Given this list of marker genes TYRO3, LDLRAP1, FAM20B, VSTM4, TENM4, PSEN2 (NCBI Gene Id 5664), RAB11FIP3, SETD4, ABCD2, LSM4, GAB1, DNAH2, CREG1, NOTCH1 (notch receptor 1), IGFBP4, PILRA, TMC7, PALD1, C2CD2, KRT1, UBTD1, CTTN, BAG3, MAPKBP1, RASSF3, SEZ6L2, UNC13B, DOT1L, TTF1, ALDH1L1 (NCBI Gene Id 10840), ST6GALNAC2, GLI2, SSUH2 (ssu-2 homolog), ALDOAP2, TPP1, ANGPTL3, GPD1, AATK, MYO7A, DOK3, FABP4, NUAK1, BBOF1, PELP1, HACD4, MAGED1, SYNPO, AQP1, MUC15, GBP6, OPTN (NCBI Gene Id 337928), ADAMTSL2, SNX8, ARL4A (ADP ribosylation factor like GTPase 4A), ACTL6B, IL18, IGSF8, CCL22, LRP1, SLC12A7, MRAS, ARAP1, SCAMP5, TMEM117, ARHGAP23, GTF2IRD1, PPARGC1B, C4orf54, NCEH1, FNDC10, QNG1, RIMS3, RENBP, TGM1, GCNT1, ESRRA, AGTRAP, TEF (TEF transcription factor, PAR bZIP family member), AVEN, NHSL1, LGMN, TTC28, SRRM2, AAGAB, MBOAT2, NOC2L, TOLLIP, TKFC, ZNF687, DBI, GXYLT2, FBLIM1 (filamin binding LIM protein 1), PEX11A, ZDBF2, LAMP1, TSPAN10, AVPR2, NDUFA5, ALDH5A1, TBC1D2B, RTP3, ABCC5, TRIM47, GLT8D1, MARCHF3, ARRB1, FABP5, CHD5, GATA1, SLCO2B1, PNLDC1, CTSB, FADS1, SAA1, MS4A7, VPS37D, RCC1, SLC46A2, ZNF703, CHRM3, SLC1A3, STARD8, BCL2L1, KCNJ9, CEBPB, MRAP, SUSD1, PRRT1, WDFY2, LAMA3, SH3BP2, SAMD4A, SQOR, RFTN2, KIAA0513, ADGRG6, SLC13A2, ENPP1, SIRPA, ACP2, PROM1 (NCBI Gene Id 9634), TF, SYNE2, BTNL9, PNPLA3, MYOM1, ATP1A1, CBR1, CAMKV, SH3BP5, FAM168A, MAG, GNA12, HEXA, AHSP, MYO10, SYNGR3, PDGFB, B3GLCT, PAQR9, TCN2, EPHA8, NCKAP5L, ADGRV1, ITSN1 (intersectin 1), ATP13A2, RXRA, ULK1, CADPS2, PRICKLE2, PLEKHG4, TMEM141, RAB17, FAM162A, ETV5, ENGASE, ACOT11, TMEM208, KIF1B, ARSG, CYB5R1, ELF5, KCTD6, SDC3, ZNF629, OCRL, GPR20, RAB34, GALNT6, SLC4A1 (solute carrier family 4 member 1 (Diego blood group)), HPN, FPR2, CDK6, FCGRT (Fc gamma receptor and transporter), CDH1, KIF7, ABCG1, PLD1, here is a description of the gene set: species: Homo sapiens Genes up-regulated in resting CD8 T cells: wildtype versus MIR155 knockout. MicroRNA-155 (miR-155) is upregulated in primary effector CD8 T cells but is expressed at low amounts in naïve cells. Anti-viral CD8 T cell responses and viral clearance were impaired in miR-155 deficient (bic-/-) mice, and this defect was intrinsic to CD8 T cells, as adoptively transferred bic-/- CD8 T cells generated greatly reduced primary and memory responses during infection. To understand the mechanism by which miR-155 regulates CD8 T cell activation, we analyzed the gene expression profiles of naive and in vitro activated wild-type and bic-/- CD8 T cells. from publication Gracias DT, Stelekati E, Hope JL, Boesteanu AC, Doering TA, Norton J, Mueller YM, Fraietta JA, Wherry EJ, Turner M, Katsikis PD (PMID 23603793) Human Gene Set: GSE44649_WT_VS_MIR155_KO_NAIVE_CD8_TCELL_UP